Given this list of marker genes DCK, AK6, UPB1, GART (NCBI Gene Id 2618), DPYS, NUDT2, CAD, GUK1, AK5, HPRT1, ADK, PPAT, AMPD1, CMPK2, AK9, ADSL, AK4, TJP2, DGUOK, UPP1, UCK1, UMPS, IMPDH1, CMPK1, DUT, NT5M, PNP, IMPDH2, UCK2, DCTD, AK8, CDA, PRPS2, LRGUK, XDH, CASK, APRT, AMPD3, TK2, MPP1, NT5C1A, PAICS, DHODH (dihydroorotate dehydrogenase (quinone)), DLG1, UPRT, DNPH1, UPP2, PRTFDC1, TYMP, TK1, NT5C, ATIC, DPYD, GDA, AK1, ENTPD8, SHMT1, AMPD2, RFK, GMPR2, PFAS, ADSS2, ADSS1, PRPS1, DLG2, GMPS, ADA, TYMS, AK2, UCKL1, PRPS1L1, CARD11, AK7, MAGI3, NT5C2, AK3, NT5E, here is a description of the gene set: Human Gene Set: GOBP_NUCLEOSIDE_MONOPHOSPHATE_METABOLIC_PROCESS The chemical reactions and pathways involving a nucleoside monophosphate, a compound consisting of a nucleobase linked to a deoxyribose or ribose sugar esterified with phosphate on the sugar. species: Homo sapiens